Given this list of marker genes TRADD, TICAM1, CASP9, RIPK1, MAGED1, DAPK3, LY96, TNFSF10, TNFRSF10A, UNC5B, TICAM2, CASP8, DCC, TNFRSF10B, CFLAR, CD14, UNC5A, FADD, DAPK2, TRAF2, APPL1, CASP3, TLR4, FAS, DAPK1, FASLG (NCBI Gene Id 356), here is a description of the gene set: Caspase activation via extrinsic apoptotic signalling pathway Human Gene Set: REACTOME_CASPASE_ACTIVATION_VIA_EXTRINSIC_APOPTOTIC_SIGNALLING_PATHWAY species: Homo sapiens